Given this list of marker genes Mmp12, Gfus, Rras, Plpp3, Dicer1, Rin2, Fut1, Sec1, here is a description of the gene set: species: Mus musculus The binding of an endothelial cell to the extracellular matrix via fibronectin. Mouse Gene Set: GOBP_ENDOTHELIAL_CELL_MATRIX_ADHESION_VIA_FIBRONECTIN